Given this list of marker genes ZDHHC20, ATP6V1C1, ATP6V1E1, ATP6V1G3, SYP (NCBI Gene Id 6855), STXBP1, ATP6V1D (ATPase H+ transporting V1 subunit D), PICALM, ATP6V0A1, ZDHHC2, ATP6V1A, ATP6V0C, ATP6AP1, ATP6V1B1, DLG4, ATP6V1B2, CLCN3, ATP6V1G1, ATP6V1F, SNAPIN, RAB3A, ATP6V1G2, ATP6AP2, ATP6V0D1, ZDHHC15, ATP6V0A4, SLC17A7, here is a description of the gene set: studied in species Homo sapiens Steps required to form an initiated synaptic vesicle into a fully formed and transmissible synaptic vesicle. Human Gene Set: GOBP_SYNAPTIC_VESICLE_MATURATION